Given this list of marker genes C2CD3, TICAM1, RAB31, CCL4, SPTLC2, H2BC21, LMO4, MX2 (NCBI Gene Id 4600), ELL2, IFIT2, MSC (NCBI Gene Id 9242), PTP4A1, TRIM21, PSMD8, COX5A, RSAD2, PLAUR, IL3RA, LILRB4, CPSF6, PROCR, CRK, CSTF2, RBP4, BUD31, H2BC7, H2BC14, SRSF10, TUBG1, MAP4K4, TLK2, PRPF3 (pre-mRNA processing factor 3), RGL1, MYBL2, TGM2, CXCL1, EWSR1, FLOT1, N4BP1, TRIM22, UGCG, PPP1R15A (protein phosphatase 1 regulatory subunit 15A), NR0B1, TAP1, PRPF4, PTK2B, H2BC12, EIF4A3, SLC25A13, ATF5, BCL11A, SPINK1, IFI44, KLF10, DGUOK, AVP, ZNF391, OASL, H2AC6, NDUFA6, SP100, HOXA4, SNX4, SP110 (SP110 nuclear body protein), UPF2, WDR47, U2AF1, MAD2L1BP, LARS2, MMP14, XAF1, S100A10, MED6, CMTR1 (NCBI Gene Id 23070), ALCAM, KIN, HNRNPAB, IL6, STX11 (syntaxin 11), MAFF, ELN, SRP54, PSMC1, H2BC6, UCK2, TRAF3, RNF19B, NDEL1, CDKN1A, IFI35 (NCBI Gene Id 3430), MED7, NAT1, GART, LRP8, GMFB, CKB, MX1, NFKBIB, UPP1, SCGB2A1, IFIT3, SPAG7, ZNF175, TAP2, PPP4R1, CD2AP, TRIP4, TDRD7, STOML1, MRPS11, GPSM2, PSMB8, HINFP, H2BC11, PSMD3, BAG1, GUK1, NUP62, CCL8, MYO1E, MED13, IFIT1, SNRPB (NCBI Gene Id 6628), UBE2L3, CCL7, SPOP, STAU1, PSMB5, FRG1, GOSR1, ST3GAL5 (ST3 beta-galactoside alpha-2,3-sialyltransferase 5), ZNRD2, OSGIN2, PGAM1, CCL2, H2BC13, SNW1, AHSA1, SUPT20H, ZNF207, FKBP15 (FKBP prolyl isomerase family member 15), PPP2R2A, ITGA7, PDE6H, PSMB7, SDF2, CXCL3, MRPL12 (mitochondrial ribosomal protein L12), JMJD6, PSMD1, ME2, CASP5, JAG2, EMP1, CEP152, UBE2V2, IFITM3, HAX1, FICD, LARP4, CRLF3, RHOBTB3, HRH1, ZNF143, CFLAR, CCR1, PCMT1, TUBB4A, LAIR2, ATP6V1E1, CDS1, CDK17, ZBTB43, CHUK, TMEM87A, GOSR2, EPM2AIP1, ARPC1A, KPNA3, BCL7B, EIF4E, IL1B, NINJ1, BET1, TOR1B, PFKP, TRAFD1, P4HA2, TNPO3, BARD1, PIK3C3, DNAJC7, TBCC, LGALS3BP, GABPB1 (NCBI Gene Id 82963), RPP38, TUSC2, DCAF4, PSMD11, here is a description of the gene set: Germinal centers (GCs) are clusters of activated B cells built on stromal cells known as follicular dendritic cells (FDCs). In the Peyer’s patches (PPs), GCs are chronically induced by bacteria and are the major sites for generation of gut IgA immune responses. Whether FDCs directly contribute to the IgA production in PP GCs is unknown. To investigate the role FDCs in gut immune system, we examined comprehensive gene profiles of FDCs purified from PPs or perypheral lymph nodes (pLNs) with or without immunization. We also tried to reconstitute the PP FDC signature in vitro by pulsed or continuous stimulation of pLN FDCs through TLRs, RARs or simultaneously through TLRs and RARs. Genes down-regulated in ex vivo follicular dendritic cells: peripheral lymph node versus Peyers patch. Human Gene Set: GSE19401_PLN_VS_PEYERS_PATCH_FOLLICULAR_DC_DN from publication Suzuki K, Maruya M, Kawamoto S, Sitnik K, Kitamura H, Agace WW, Fagarasan S (PMID 20643338) studied in species Homo sapiens